The following is a description of a gene set: species: Homo sapiens Binding to a protein or protein complex that results in the connection of a bundle of His cell with a Purkinje myocyte and contributes to the communication between the two cells. Human Gene Set: GOMF_CELL_ADHESIVE_PROTEIN_BINDING_INVOLVED_IN_BUNDLE_OF_HIS_CELL_PURKINJE_MYOCYTE_COMMUNICATION, and this is the list of marker genes: DSG2, PKP2, DSC2, JUP, DSP